The following is a description of a gene set: Cytokines mediate cell-cell communication in the immune system and represent important therapeutic targets. A myriad of studies have highlighted their central role in immune function, yet we lack a global view of the cellular responses of each immune cell type to each cytokine. To address this gap, the authors created the Immune Dictionary, a compendium of single-cell transcriptomic profiles of more than 17 immune cell types in response to each of 86 cytokines (>1,400 cytokine-cell type combinations) in mouse lymph nodes in vivo. A cytokine-centric view of the dictionary revealed that most cytokines induce highly cell-type-specific responses. For example, the inflammatory cytokine interleukin-1β induces distinct gene programmes in almost every cell type. A cell-type-centric view of the dictionary identified more than 66 cytokine-driven cellular polarization states across immune cell types, including previously uncharacterized states such as an interleukin-18-induced polyfunctional natural killer cell state. from publication Cui A, Huang T, Li S, Ma A, Pérez JL, Sander C, Keskin DB, Wu CJ, Fraenkel E, Hacohen N (PMID 38057668) studied in species Mus musculus Genes negatively differentially expressed in cell type: cDC2 (conventional dendritic cell type 2) upon treatment with cytokine: IL-9 in mouse lymph nodes in vivo. Mouse Gene Set: CUI_CDC2_IL9_RESPONSE_DN, and this is the list of marker genes: Tsc22d3, Foxp1, Fos, Klhl24, Btg2